The following is a description of a gene set: studied in species Mus musculus Transport of substances into, out of or within a peroxisome, a small, membrane-bounded organelle that uses dioxygen (O2) to oxidize organic molecules. Mouse Gene Set: GOBP_PEROXISOMAL_TRANSPORT, and this is the list of marker genes: Pex14, Pex5, Pex6, Trim37, Pex13, Pex7, Pex19, Lonp2, Rab8b, Pex10, Pex26, Pex1, Pex12, Abcd4, Usp9x, Pex3, Pex5l, Abcd1, Pex2, Pex16, Abcd3, Abcd2